Given this list of marker genes RNU7-119P, HSD3BP5, PLAAT5, KCNJ12, LINC00314, TCF21, HSD3BP2, LINC02759, RPL17P13, RTL9, POU6F2, PKP1, GATA6-AS1, DES, LINC01133, LINC02307, FMO1 (NCBI Gene Id 2326), GBX2-AS1, ASB18, LINC01673, GDNF, CDH15, FGF10-AS1, NCKAP5-AS2, CYP2W1, EEF1DP3, CNTN5, ENSG00000251216, GLI2, ENSG00000272668, SLC24A2, SLC18A3, SLIT2, CACNA2D4, SLC22A2, LINC01695, ACKR1, ZNF804B, CADM3, LINC02360, CLMP, ITGBL1, SLC16A10, SLC19A4P, NGF (NCBI Gene Id 4803), OACYLP, STC1, PCDH10, MATN1, CNTN6, NALCN, MYOD1, RPL31P25, LINC00523, CCNYL2, LINC02277, PITX1, COL8A2, ASZ1 (ankyrin repeat, SAM and basic leucine zipper domain containing 1), SELENBP1, COL16A1, LINC01931, ELN, SYT15, WSCD2, KCNIP4, LINC02708, SFTPD, GDNF-AS1, MMP23B, ENSG00000250092, PON3, MSC-AS1, SLC6A15, LINC02006, HS3ST6, LINC02893, OCA2, FREM1, MIR218-1, KCTD19, ARHGAP15-AS1, SFTPD-AS1, LINC02268, ASB4 (NCBI Gene Id 51666), ENSG00000244137, GXYLT2, PTGFR, RSPO2, GDF6 (NCBI Gene Id 9571), C1QTNF2, LIN7A, MATN2, NFASC, here is a description of the gene set: The gene expression program underlying the specification of human cell types is of fundamental interest. The study authors generated human cell atlases of gene expression and chromatin accessibility in fetal tissues. For gene expression, the study authors applied three-level combinatorial indexing to >110 samples representing 15 organs, ultimately profiling ~4 million single cells. The study authors leveraged the literature and other atlases to identify and annotate hundreds of cell types and subtypes, both within and across tissues. Our analyses focused on organ-specific specializations of broadly distributed cell types (such as blood, endothelial, and epithelial), sites of fetal erythropoiesis (which notably included the adrenal gland), and integration with mouse developmental atlases (such as conserved specification of blood cells). These data represent a rich resource for the exploration of in vivo human gene expression in diverse tissues and cell types. Human Gene Set: DESCARTES_FETAL_PLACENTA_STROMAL_CELLS from publication Cao J, O'Day DR, Pliner HA, Kingsley PD, Deng M, Daza RM, Zager MA, Aldinger KA, Blecher-Gonen R, Zhang F, Spielmann M, Palis J, Doherty D, Steemers FJ, Glass IA, Trapnell C, Shendure J (PMID 33184181) Marker genes curated from the annotated cluster as represented in the Descartes Human Gene Expression During Development database. studied in species Homo sapiens